Given this list of marker genes Ptma, Tmsb10, Pfn1, Atm, Itk, Ltf, Ndufa13, Rpl13a, Baz1a, Ptprcap, Oaz1, Rnaset2b, Bcl9l (B cell CLL/lymphoma 9-like), Senp6, Xpot, Wipf1, Atp10d, Cycs, Eno1b, Fth1, Gramd2b (GRAM domain containing 2B), Ubb-ps, Cfl1, Ubald2, Prpf4b, Lag3, Anp32a, Retnlg (resistin like gamma), Lime1, Snrpc, Psmb8, Ubb, Atxn2, Thy1, Cd3g, Lfng, Chaserr, Fxyd5, Prr13, Itch, Flicr (NCBI Gene Id 78185), here is a description of the gene set: Mouse Gene Set: TABULA_MURIS_SENIS_MARROW_CD4_POSITIVE_ALPHA_BETA_T_CELL_AGEING studied in species Mus musculus from publication Tabula Muris Consortium (PMID 32669714)